Given this list of marker genes Car2, Pon1, Apmap, Pon2, Pon3, Car1, here is a description of the gene set: Catalysis of the reaction: a phenyl acetate + H2O = a phenol + acetate. studied in species Mus musculus Mouse Gene Set: GOMF_ARYLESTERASE_ACTIVITY